The following is a description of a gene set: species: Homo sapiens Human Gene Set: chr10q26, and this is the list of marker genes: BNIP3, EDRF1-DT, PRDX3, DMBT1L1, SEC23IP, LINC02646, TUBGCP2, HMX3 (H6 family homeobox 3), TCERG1L-AS1, RAB11FIP2, MIR3941, CPXM2, CUZD1, NPM1P31, DUX4L13, INPP5F, RPS8P4, ALDOAP2, TCERG1L, DUX4L12, OR6L1P, CLRN3, RNU6-728P, C10orf143, RN7SL749P, MIR378C, EDRF1, LINC00601, LINC03068, LINC01164, FAM53B, LINC02666, DUX4L24, SPADH, ARMS2, SFXN4, NSMCE4A, RPS26P39, LINC02870, CASC2, BAG3, CTAGE7P, ABRAXAS2, EMX2OS, SYCE1, FANK1, C10orf88B, UTF1, C10orf88, MKI67, SLC25A18P1, SCART1, AGGF1P2, RN7SL846P, WDR11, ENSG00000236426, GNG10P1, FAM24B, LINC02674, CACUL1 (CDK2 associated cullin domain 1), DUX4L15, NACAP2, PLEKHA1, RAD1P1 (RAD1 pseudogene 1), LHPP, KNDC1, LINC01153, BUB1P1, DMBT1, GPR26, ENSG00000297055, DENND10, GRK5, LINC02667, ENSG00000199321, RPL17P36, WDR11-DT, EBF3, FAM24A, CALY, VENTX, EBF3-AS1, HTRA1, YBX2P1, TEX36, FOXI2, ECHS1, ENSG00000222588, DUX4L29 (NCBI Gene Id 106481970), LDHAP5, LINC03036, IKZF5, PAOX, ADAM8, FAM204A, UROS, DUX4L21 (NCBI Gene Id 102723518), FANK1-AS1, RPS10P18, MIR202, LINC01561, SPRN, ENSG00000287326, ADGRA1-AS1, FUOM, MTG1, ZNF511, BTBD16, NKX6-2, ACADSB, MIR4296, FAM53B-AS1, DUX4L28, INPP5A, INSYN2A, GLRX3, CTBP2, NANOS1, TACC2, DUX4L23, NPS, ATE1, LINC01163, LINC02930 (NCBI Gene Id 105378517), ENSG00000305153, ZNF511-PRAP1, TIAL1, EDRF1-AS1, RPL19P16, RARRES2P2, PTPRE, PPIAP32, OAT, DPYSL4, DUX4L25, LINC01166, JAKMIP3-AS1 (NCBI Gene Id 105378567), PSTK (NCBI Gene Id 118672), SNORA19, RPL23AP60, DUX4L14, RNA5SP328, MIR4297, MIR3944, PHACTR2P1 (NCBI Gene Id 100533676), HMX2, MCMBP, MRPS21P6, PRAP1, MIR4682, LINC02641 (long intergenic non-protein coding RNA 2641), LINC02944, EEF1AKMT2, ENSG00000307961, PWWP2B, C10orf90, LINC01165, ENSG00000295480, EIF3A, BANF1P2, LRRC27, RPS15AP5, BUB3, SAR1AP2, LINC01168, CFAP46, TOMM22P5, CYP2E1, DOCK1, RPL21P16, ENSG00000300585, ENSG00000289400, BCCIP, DHX32, RPS27P18, EMX2, RN7SKP167, DUX4L10, MMP21, ENSG00000223528, ADGRA1, LINC00867, DUX4L22, GRK5-IT1, C10orf120, PDZD8, OR6L2P, RPL5P28, MIR4681, MIR4484, DUX4L11, TEX36-AS1, PRLHR, ATE1OSP, TXNP1, MIR202HG, FGFR2, DUX4L20, RGS10, FRG2B, CLUHP5, ZRANB1, RNU2-42P, JAKMIP3, STK32C, ADAM12, CHST15, PLPP4 (NCBI Gene Id 196051), ENSG00000228021 (novel transcript), NKX1-2, OR7M1P, ENSG00000285955 (NCBI Gene Id 105378525), PPP2R2D, MGMT